Given this list of marker genes OR2M4, DGKQ, GPHB5, OR1D2, STK39, FBXW7-AS1, GPR85, ADCY1, F2R, RGS9BP, MIR20A, OR4K5, TAS2R19, NLN, OR4L1, OR11H6, OR4D9, CXCR1, HPGD, GNAQ, NPPB, VN1R5, ABL2, OR10Z1, GNB2, TAS2R45, PREX2, RPH3AL, OR52W1, OR4D2, CCL15, SSTR1, OR10A3, APLP2, OR4N5, ADCY10, OR5H1, GPR156, ADCY7, SMO, OR52L2P, GUCY2D, PIK3CG, GSK3A, OR13C4, OR2A14, OR4D5, OR51V1, OR10V1, ATRNL1, OR5M9 (NCBI Gene Id 81186), ACP3, GCG, GPR171, MTNR1A, S1PR1 (sphingosine-1-phosphate receptor 1), PIK3R6, ADGRB2, OR6M1, CELSR1, OR4A47, DGKA, CXCL8, KCTD8, GUCY2F, OR6S1, MPL (NCBI Gene Id 4352), OR4P4, PTGFR, PLD2, GPR32P1, BRS3, OR6K3, GPR160, INPP5A, P2RY4, FZD9, KCTD12, STAT5A, GPR88, GNGT1, OR2I1P, KCNQ1, ESR1, OR13A1, MTNR1B, TAS2R16, ATP2B4 (ATPase plasma membrane Ca2+ transporting 4), HTR1F, GSK3B, OR1C1, GPR27, DGKE, OR5D16, ADGRA2, KLK14, OR2W1, NPW, PSAPL1, XCL2, CCKBR (NCBI Gene Id 887), OR8G3P (olfactory receptor family 8 subfamily G member 3 pseudogene), OR51A7, OR6T1, ADGRE3, AKT1, OR6C74, RGS14, OPRL1, TM2D1, OR2A12, PDE2A, GPR83, OR51B6, AGT, P2RY13, FFAR1, OR1D5, OR2D2, TACR2, GNAT1, OR8J3, OR8H1, NMT2, OR4K3, ENTPD2, OR5L2, OR6C70, FPR1, PLCE1, FFAR3, HRH2, GIT2, OR2H1, ACKR2, ACE, OR9G4, GPRASP1, CNR2 (cannabinoid receptor 2), GPR37L1, OR10A6, QRFPR, P2RY12, GPR20, APLN, GALR1, OR8B12, APLP1, OR8J1, GPR87, ADGRD1, CRCP (NCBI Gene Id 27297), SLIT3, OR5B17, PPP3CA, OR5G3, OR1E1, WASF2, VAV1, HTR1D, GAP43, ADORA2A, OR8G2P (olfactory receptor family 8 subfamily G member 2 pseudogene), HOMER3, PLA2G2A, MAS1L, OR11H7, SUCNR1, OR6C4, GPR132, GPR143, NMUR1, GPR18, DTNBP1, ARR3, GNG4, ALOX15B, OPN1MW2, GAL, CCR3, GRP, HTR2A, CCL14, TAS2R60 (NCBI Gene Id 338398), LPAR3 (NCBI Gene Id 23566), PIK3R5, OR2T1, CXCL11, PYY3, CCR4, ACKR3, OR2L3, CNGB1, OR10G6, IQGAP2, OR56B4, OR5AU1, C5AR2, GPR34, CCR1, OR5B12, LMBRD2, DGKD, OR5AC1, OR1J2, OR5J2, PAX8, CRHR1, HRH4, OR10J4, OR2D3, MIR30E, RELA, OR4C11, OR2H2, OR2M5, PRKAR1A (protein kinase cAMP-dependent type I regulatory subunit alpha), PTGDR, TAS2R38, OR8H2, GP1BA, OR5B21, MARCO (macrophage receptor with collagenous structure), PLN, GRM8, OR1J1, GNG13 (G protein subunit gamma 13), OR6V1, GPR68, SLC24A4, OR2A25, WNT5A, OR8B3, NXPH2, OPN1MW, GNB1, CPE (NCBI Gene Id 1363), RXFP1, ADGRG7, ABHD6, MCHR2, RPGRIP1L, OR10H2, OR56A5, OR11L1 (olfactory receptor family 11 subfamily L member 1), OR9Q2, TAS2R7, OR10X1, SORCS2, OR8G5, HCAR1, ADGRB3, OR2B8P, TCP11, GNB3, VIPR2, RGS4, GPR33, OR4M2, OR51B4, PDC, OR10H5, CCL5, MRAP2, TAS2R14, RAPGEF2, PALM, OR52E8, RGS6, NPVF, SPHK2, VN1R1, OR7A5, OR2T27, OR2AP1, OR13G1, OR5AS1, OR52N4, GPRC5C, DRD1, OR5M3, OR52K1, GNG5, MRGPRX1, ECE1 (endothelin converting enzyme 1), PLCH2, FRMPD1, GRK5, CXCR3 (NCBI Gene Id 2833), RNF113A, RAC1 (NCBI Gene Id 5879), CAMKMT, OR4F4, OR6J1, OR11H4, OR8B8, OR2T34, OR4B1, OR5AL1, OR2A2, SLC39A14, RGS17, OR4K15, ARHGEF1, GPR157, OR10H3, ECRG4, CAV1, OR4A8, TYRO3, FYN, P2RY1, AZU1, OR2F2, OR10A5, GPRC5B, OR12D3, GPR19, OR1J4, OR1L8, ADRA2B, OR4F17, TAAR2, FZD3, TBXA2R, KLK6, OR4F29, FZD6, OR4K17, GHRL, CCL16, OR4Q2, OR8S1, OR2M7, SORCS3, OR5V1, SYP, OR5M10, DYNLT1, OR10AD1, CHRM4, GPR78, APELA, OR8K5, OR10D3, TREM2, PRKCG, OR4A15, OR10G2 (olfactory receptor family 10 subfamily G member 2), GPR141, OPN3, TENM1, TULP3, ADGRB1, GNAI3, OR2K2, OR6Q1, OR1L1, GRM6, GPER1, CCR10, NPR1, OR10K2, OR4A5, OR2AG1, XCL1, PADI2 (peptidyl arginine deiminase 2), OR2T4, FSHB, ADCY9, GPR37, KISS1, GALR3, OR10C1, CCR5, AGRN (agrin), OR5K4, NPY5R, OR4E1, OR2L5, CHRM3, GPR35, GPR82, OR52E4, ARHGEF11, OR7G3, OR5AR1, TAS2R39, FZD1, OR1L4, SORL1, GNA12, CXCL10, PTH1R, GPSM2, OR52H1, GPR149, PDE3A, OR6F1, TAS2R31, OR1N1, CCL19, OR1F12P, P2RY8, GPR119, GNG5B, ADORA3 (NCBI Gene Id 140), OPN1MW3, PDYN, OR2T7, OR52I1, GNAS, GRK4, NPY, OR2AT4, CXCR5, OR13C5, OR11H12, DRD4, OR2T11, S1PR4, ECE2, ADRA2A, OR51E2, NPBWR2, PDE4D, ENTREP1, SLC26A6, CNTN2, AKR1C2, OR4C6, NPR3, OR8U1, NCSTN, AGTRAP, FLNA, OR8U9 (olfactory receptor family 8 subfamily U member 9), RAP1GDS1, OR51C1P, GRM1, OR4F6, OR2J1 (olfactory receptor family 2 subfamily J member 1), DEFB4A, NOS1, GIPR, TAS1R3, PREX1, CCL4, CHRM5, GRPR, GPR4, OR6B1, OR1B1, ADRB1 (adrenoceptor beta 1), OR4Q3, TAS2R9, LRRK2, LYN, HTR6 (NCBI Gene Id 92230), ADRA1A, VN1R2, FZD8, SAG, OR6N2, RAPGEF3, RGS1, LGR6, CALCR, OR4C16, GPR17, VN1R4, PDGFRB (NCBI Gene Id 5159), GIT1, NPS, ENTPD1, ADM5, CGA, OR2G2, CX3CL1, OR2AK2, OR14A16, OR4S2, CHRM2, NTS, OR5H15, OR4X2 (NCBI Gene Id 81296), OR5M11, GRM5, OR8K1, MIR1-1, OR11A1, SELE, OR4X1, MC5R, PRLH, PRKD1, OR5T3, CCR2, CDK5R1, CCL13, PF4, NPY1R, SPHK1, GLP2R, RGS8, OR52E5, OXGR1, OR2M2, GPR152, LANCL1, CCL4L2, AGTR2, PLCB3, LPAR4 (lysophosphatidic acid receptor 4), STMN1, RGS19, SST, OR2AJ1, RGS21, OR2G6, GPRC5D, OR56B1, CCKAR, CHGA, OR13H1, PDE4A, OPN1LW, TFF2, FPR3, GPR52, CCL2, GPR153, APP, CCRL2, OR10T2, EDN1, OR6K6, ADGRL3, OR6B3 (olfactory receptor family 6 subfamily B member 3), SLC1A1, OR5T2, OR5A1, GALP, OR7A17, OR5D18, PTGDR2, RGS10, GNA14, ADRB2, MRGPRX4, GPR84, OR2W3, OR6C68, OR2T3, OR5H14, OR5A2, SPNS2, WNK1, OR3A2, CXCL1, GNAL, OR51D1, NTSR1, OR13C6P, OR14I1, GRM3, OR1L6, GRID1, OR52E1, OR5H6, ADGRG5, OR13C9, PMCH, OR5B2, ADCYAP1R1, OR13C3, OR6C75, OR6C6, CYSLTR2, PCSK1N, PHF24, ADRA1D, OR2L2, MLNR, TAS2R41, LPAR2 (NCBI Gene Id 9170), LPAR5 (lysophosphatidic acid receptor 5), CCR9, INSL3, F2RL2, OR10D4P, P2RY6, OR11H1, OR2T5, OR1G1, ABCA1, OR8U3, RXFP4, ADM2, OR4D6, OR2F1, OR10G3, CAV2, KLK5, OR1D4, OR4N2, ZNF219, TAS1R1 (taste 1 receptor member 1), AKAP12, ARRDC3, OR6C3, PROKR1, APOE, RGS16, PHB1, FZD7, CNR1, ITGB3, FZD2, ROCK2 (Rho associated coiled-coil containing protein kinase 2), OR51B5, CCL25, TAAR8 (trace amine associated receptor 8), OR10G7, PROKR2, OR1P1, HTR2C, OR4D1, OR5M8, OR2L8, PLPPR4, OR51I2, TAC3, GPR39, TUB, GLP1R, OR1A1, VPS54, CASR, OR13J1, ARRB2, GNAT3, UCN, NMU, ADGRL2, OR4K14, RASGRP4, CCL26, OR2M3, BCAR1, OR5L1, RIC8B, CXCR2, FFAR2, TAS2R43, SSTR5, OR7C1, GNG2, FZD5, NHERF1, GPR21, GPRC6A, ADCY8, GAST, OR4F15, BECN2, OR8K3, FCN1, UCN2, ADGRL1, RGS9, ADM, OR10H1, GNA15, SNCA, OR10S1, HCAR3, CAMK2A, RGS20, OR4A4P, OR51F1, VIPR1, MRGPRX2, ADGRF3, ADCYAP1, OR1N2, OR8H3, OR6C1, GPR176, ROCK1, MRGPRF, DGKG, OR9A1P, NMBR (neuromedin B receptor), GPR179, DEPTOR, GPR146, SLIT2, UTS2R, OR5K2, UCN3, OR2A1, OR2AE1, TAAR5, ADCY4, GAS2L2, OXTR, CGB3, F2, FPR2, SSTR3, GABBR2, OR2A4, CACNA1D, GPR12, OR52L1, RASD1, GPR15LG, OR52E2, OR8A1 (NCBI Gene Id 390275), CRHR2, FGF8, AVPR1B, ADRA2C, NTSR2, OR2T33, PTGER1, CCR6, OR7D2, MIR143, RHO, CHRM1 (cholinergic receptor muscarinic 1), PLEK, OR1S2, VPS35, SORT1, OR51S1 (olfactory receptor family 51 subfamily S member 1), NPY4R2, HCRTR1, ACKR1, LPAR1, TRHR, OR2T12, TAS1R2, FRS2, AVPR2, OR52D1, GNB5, ZDHHC3, RGS12, MGLL, OR5D14 (olfactory receptor family 5 subfamily D member 14), DEFB1, GLRA1, SORCS1, OR52J3, OR8D4, AIPL1, C3AR1, OR10J5, TAS2R40, OR2C1, ARRB1, ADGRF1, GPR55, OR1K1, PARD3, OR5W2, GRM4, CGB2, WBP1L, PDE10A, RAPGEF4, PRMT5, CCL1, OR11G2, CRTC3, PRKAR2B, UBQLN2, ORAI1, OR1E3, ADRA1B, TMOD2, OR10Q1, CALCRL, MCHR1, OR6X1 (olfactory receptor family 6 subfamily X member 1), TAC4 (NCBI Gene Id 337948), PRKACB, MC2R, CRKL, SLC39A9, PTGER4, F2RL3, ADGRG3, OPN4, DRD5, OR8J2, CX3CR1, AHCYL1, NRXN1, SSTR2, CORT, PROK2, GCGR, OR6A2, OR1L3, CCL22, GPR42, OR2B2, GNG7, OR6C2, SCN11A, GLRA2, GRM7, CIB1, RAMP2, ADGRD2 (NCBI Gene Id 347088), GPR161, LGR5, APOA1, OR7A2P, CALM2, OR2Z1, NXPH3, CXCL9, OR4C46, MAS1, OR2AG2, OR52A1, YWHAB, TAS2R50, GNG14, CCL21, OR4F21, ITPR3, HRH3, BCAR3, CCR8, GRK6, ADORA1, MC3R, RGR, MRAP, ACKR4, MIR133A1, OR9I1, OR8G1, GTF2H2, IL2, NMUR2, OR6P1, OR52N2, OR51E1, CALM3, TAS2R1, OR52N5, CCL3, OR13C7, ABL1, SIGMAR1, OR9A4, OR8U8, F2RL1, LHCGR (luteinizing hormone/choriogonadotropin receptor), ADGRG4, RAC2 (NCBI Gene Id 5880), LTB4R2, NPY6R, OR52N1, MC1R, HOMER1, GPR151, NPY2R, GPR162, OR4C3, OR7D4, RIT2, OR14J1, NECAB2, ADGRF2P, OR51A4, OR10P1, XCR1, HOMER2, DGKK, KCNK2, OR6B2, GNRHR2, RGS5, ADGRG6, OR2T6, TAS2R8, GRM2, CD3E, GIPC1, LPAR6, RAMP3, NPBWR1, PCP2, MRGPRD, OPRD1, OR2B11, FSHR, OR4C12, GNRHR, TPRA1, BICD1, INPP5K, ADCY5, OR2T2, ULK4, AREG, GPR45, PRKCB, OR14C36, GPR50, CGB1, ADGRV1, OR2L13, KLF16, RBM15, OR2T35, OR4E2, ARHGEF12, GPR32, TAPT1, PDE4B, CCL8, GNGT2, MIR101-1, OR51L1, GNB4, CCL18, OR4D11, GHRHR, GPR63, OR5AP2, GNAO1, OR8I2, OR4D10, OR7G1, TSHR, OR51H1, GALR2, PDE6G, ZDHHC21, BAIAP3, OR52B6, PPY, DGKH, OR7G2, TAAR6 (trace amine associated receptor 6), OR4F16, ADCY2, OR5AN1, OR52Z1P, OR10A4, GPR142, OR1F1, NMB, PLCB4, NPB, S1PR2, OR4C15, CXCL12, PKD2, HCAR2, CELSR3, LGR4, MAPK7, KISS1R, OR13F1, AKR1C3, OR2T29, CCR7, AGRP, ITPR1, TAS2R5 (taste 2 receptor member 5), OR4K2, OR2B3, QRFP, OR9G9, OR4K1, OR2A5, ADA, GPBAR1, ADGRF4, ACTN2, GPR65, PLCB2, GPR173, HTR4, ADRB3, OR12D2, OR2V2, GPR3 (NCBI Gene Id 2827), PTHLH, HCRTR2, OPRK1 (opioid receptor kappa 1), TAS2R3, FOXC1 (NCBI Gene Id 3666), PLPP1, OR7A10, OR2J2, RRH, NLRP6, LTB4R, OR5B3, NPFFR1, OR52K2, EDNRA, OR4S1, TAAR1, OR5P3, OR5BS1P, SCG5, RAPGEFL1, OR11H2, VN1R3 (NCBI Gene Id 317702), HCRT, CELSR2, OR10A2 (olfactory receptor family 10 subfamily A member 2), BDKRB2, C5AR1, OR2J3, PLCB1, GPR26, AKAP6 (NCBI Gene Id 9472), OR10K1, OR2T10, RGS18, PDCL, BHLHA15, APOC3, IGF2R, OR10A7, PTGIR, SCTR, ADGRE2, OR2B6, OR56A3, ANXA1, OR51B2, GPR31, OR52B2, P2RY2, EZR (NCBI Gene Id 7430), PTH2, S1PR3, CALCA, TAS2R20 (NCBI Gene Id 266660), PSAP, DRD3 (dopamine receptor D3), JAK2, VIP, OPN1SW, OR2Y1, FFAR4, GLRB, CCK, OR56A1, CXCL13, CYSLTR1, ADORA2B, OR13C8, OR51G1, PRKCA, NXPH4 (NCBI Gene Id 11247), HTR1E, HIF1A, RORB, GPR183, GPRC5A, ADGRF5, GNG8, RGS13, OR4A16, GPR150, ADCY6, OR2W5P, GPR101, OR5K3, PTGER2, ZDHHC7, OR51F2, TAFA5, OR10G8, OR10AC1, GRK7, GNAT2, TAAR9, INSR, PRKACA, PNOC, USP33, GNAI1, OR9G1, OR4F3, GPR22, GRK1, RIMS2, RGS2, OR4F5, PRLHR, OR4C45, GNAI2, OR2A7, RGS11, MRGPRG, PDE3B, OPRM1, OR52P1, CCL24, ADGRE5, NPFF, GNAZ, MRGPRE, OR14K1, NPPA, OR5F1, TAS2R13, PYY, ADGRA1, CALCB, ADGRE1, OR52M1, CXCR4, OR5T1, OR51J1, CCL3L3, OR1F2P (olfactory receptor family 1 subfamily F member 2 pseudogene), OR7E24, GPR199P, ADGRG1, S1PR5, OR52B4, OR3A1, HRH1, DRD2, OR6C65, OR52E6, RACK1, EDNRB, OR52A5, GPR6, CDC42, TSHB, OR5AC2, OR1I1, CCL23 (C-C motif chemokine ligand 23), MGRN1 (mahogunin ring finger 1), GPR182, HTR5A, OR8B2, HTR1A, TRPM1, P2RY14, NMT1, LHB, CRY1, PRKAR1B, MFSD2B, OR5D13, OR9A2, OR52R1, MC4R, RGS7, OR4M1, ANO1, PRKD3, OR1E2, TACR3, APLNR, PTPN6, SH2B3, GRIK3, GRK3, HTR1B (5-hydroxytryptamine receptor 1B), OR4K13, OR51G2, GPR25, TAC1, GPR75, GHRH (growth hormone releasing hormone), CXCL6 (C-X-C motif chemokine ligand 6), GPR135, TACR1, OR8D1, ADGRA3, OXER1, VN1R17P, HTR2B, GNA13, OR10H4, OR51I1, P2RY10, GNA11, FZD10 (frizzled class receptor 10), KCTD16, GPR158, BDKRB1, OR4C5, CA2, OR2T8, OR10J1, GABBR1, PTK2B, DGKZ, OR1M1, SCT, TAS2R4, AKAP5 (NCBI Gene Id 9495), OR7C2, OR1A2, OR51M1, OR2S2, ALK, CXCR6, OR13C2, C14orf28 (NCBI Gene Id 122525), OR52A4P, AGTR1, VEGFA, CCL7, MIR145, OR10J3, C5, OR51Q1, SIX1, OR5H8, USP20, OR51T1, GPR148, OR51A2, OR14A2 (olfactory receptor family 14 subfamily A member 2), NPY4R, CMKLR2, GPR61, OR5I1, OR4N4, OR5C1, CALM1, FZD4, TAAR3P, OR13D1, SRC, TAS2R10, PPARG, OR10J6P, PRKD2, SSTR4, TGM2, NPFFR2, OR5AK3P, MET, GRK2, OR8D2, OR2A42, GPR62, OR3A3, CMKLR1, OXSR1, OR10G9 (olfactory receptor family 10 subfamily G member 9), GNG3, OR12D1, GPR15, ECEL1, RXFP2, OR5P2 (NCBI Gene Id 79279), CCL11, OR5AK2, PDGFRL, PTH, PPP1R9B (NCBI Gene Id 84687), TAS2R42, OR14L1, RAMP1, C3, OR2V1, ADGRL4, DGKI, ADGRG2, AVPR1A, OR9Q1, OR1S1, PIK3CB, GPHA2, OR8B4, OR5M1, ROBO1, THPO, RIC8A, OR10W1, GPR139, GIP, CGB7, TMEM145, OR2C3, GNG10, PENK, DGKB, PTAFR, INS, OR2W6P, RGS7BP, GNG12, PTH2R, RXFP3, OR10G4, OR9K2, OR6K2, MRGPRX3, OR52I2, GPR174, OR56B2P, GHSR, OR2G3, OR5H2, AKAP13, OR1Q1, PRKAR2A, HTR7, OR4M2B, POMC, PTGER3, RGS3, OR6N1, ADCY3, OPN5, GPR180, IAPP, PDE6H, OR10AG1, CARTPT, P2RY11, EREG, NPSR1 (NCBI Gene Id 401323), OR6Y1, NMS, TAS2R30, GNG11, OR10R2, OR56A4, OR6C76, TAS2R46, OR4C13, FAM114A1, OR5K1, here is a description of the gene set: Human Gene Set: GOBP_G_PROTEIN_COUPLED_RECEPTOR_SIGNALING_PATHWAY studied in species Homo sapiens The series of molecular signals initiated by a ligand binding to its receptor, in which the activated receptor promotes the exchange of GDP for GTP on the alpha-subunit of an associated heterotrimeric G-protein complex. The GTP-bound activated alpha-G-protein then dissociates from the beta- and gamma-subunits to further transmit the signal within the cell. The pathway begins with receptor-ligand interaction, and ends with regulation of a downstream cellular process. The pathway can start from the plasma membrane, Golgi or nuclear membrane.